The following is a description of a gene set: studied in species Homo sapiens Catalysis of the reaction: acetyl-CoA + histone H4 L-lysine (position 5) = CoA + histone H4 N6-acetyl-L-lysine (position 5). Human Gene Set: GOMF_HISTONE_H4K5_ACETYLTRANSFERASE_ACTIVITY, and this is the list of marker genes: JADE1, BRPF1, JADE2, KAT6A, MEAF6, ING4, ING3, BRD1, KAT7, BRPF3, KAT8